The following is a description of a gene set: Chromatin modifications during the maternal to zygotic transition (MZT) Human Gene Set: REACTOME_CHROMATIN_MODIFICATIONS_DURING_THE_MATERNAL_TO_ZYGOTIC_TRANSITION_MZT species: Homo sapiens, and this is the list of marker genes: H2AC4, H3C4, H3-3B, H2BC14, H2BC7, H2AX, H2AC14, H3C3, H3C11, H2BC6, H2BC17, H2AC18, H3C15, H4C16, H2AC19, H3C13, H2AC8, H2AC7, H3C2, H2AB1, H2BC12, H3C7, H2AC6, H2AC20, TET3, H4C8, AICDA, H2BC5, H4C3, KDM5A, H2BC15, H2BC11, METTL23 (methyltransferase 23, arginine), H2BC4, H3C10, UHRF1, H3-3A, H4C1, H2BC21 (H2B clustered histone 21), H3C6, H4C15, H2AJ, H4C6 (H4 clustered histone 6), H2BC9, H4C14, H3C1, H4C4, KDM6A, KDM6B, H3C8, H2AZ2, H2BC8, UNG, H3C12, H2BC3, H4C12, H4C9, DPPA3 (developmental pluripotency associated 3), H2BC26, H2BC1, H4C11, H2BC12L, KDM5B, STPG4, H2BC10, H4C5, H4C2, H3C14, H2BC13, H4C13